Given this list of marker genes SLC44A1, FLVCR1, RHAG, SLC44A2, FLVCR2 (NCBI Gene Id 55640), SLC22A2, AQP8, SLC22A16, here is a description of the gene set: studied in species Homo sapiens Human Gene Set: GOMF_AMINE_TRANSMEMBRANE_TRANSPORTER_ACTIVITY Enables the transfer of amines, including polyamines, from one side of a membrane to the other. Amines are organic compounds that are weakly basic in character and contain an amino (-NH2) or substituted amino group.